The following is a description of a gene set: species: Homo sapiens Cellular Senescence Human Gene Set: REACTOME_CELLULAR_SENESCENCE, and this is the list of marker genes: H3-3A, TINF2, STAT3, H2BC12L, H2BC1, CCNE2, MAP4K4, CBX8, H3-4, H2BC12, IL1A, H2BC10, H2BC9, H2BC21, H2AC18, ACD, H4C5, CDC16, MAPKAPK3 (MAPK activated protein kinase 3), H2BC11, MIR24-2, PHC3, H3C7, PHC2, H1-0, H2BC7, RNF2, SUZ12, CDK2, RING1, MAPK11, H2BC4, H2BC26, H3C14, H3-3B, KDM6B, H3C1, H4C8, CDC26, H4C14, H1-4, TFDP2, MAP2K6, MAPKAPK2, MAPK14, H1-1, ANAPC4, ANAPC16, H4C6, CDKN2B, H4C2, H1-5, CDKN2C, ETS1, BMI1, ATM, RBBP7, VENTX, MAPK8, RPS6KA1, KAT5, ERF, MDM2, EED, MAP3K5 (NCBI Gene Id 4217), EZH2, H4C9, CDC23, CXCL8, ANAPC11, H3C2, CDKN2A (cyclin dependent kinase inhibitor 2A), ANAPC7, CDKN1A, TNRC6C, TERF1, AGO1, CABIN1, H3C3, UBC, MAPK1, CDC27, CDKN1B, RELA, H3C4, ID1, H4C15, HMGA2, MDM4, MAPKAPK5, CBX6, H2AC19, TERF2IP, MRE11, H3C12, H4C16, UBE2E1, FZR1, EHMT1, MAP2K4, TNIK, CCNA2, MAPK3, RBBP4, CCNE1, H2BC6, CDK4, H2AB1, E2F1, AGO3, UBB, CDKN2D, EP400 (E1A binding protein p400), RB1, H2BC14, MAP2K3 (mitogen-activated protein kinase kinase 3), H3C6, UBA52, RPS6KA2, H2AC7, H2AZ2, FOS, HMGA1, UBN1, H3C15, UBE2C, UBE2D1, H4C1, CCNA1, TP53, ANAPC10, H2BC8, TFDP1, ASF1A, PHC1, H3C8, CDK6, H4C12, H2AX, IGFBP7, IL6, H4C11, TXN, H2AC14, IFNB1, RAD50, TNRC6B, ETS2, JUN (NCBI Gene Id 3725), H4C3, SP1, EHMT2, MAPK9, TNRC6A, MIR24-1, ANAPC1, E2F3, H1-2, H2BC13, RPS6KA3, H2BC5, AGO4, H1-3, H2BC17, H2AC20, H3C10, H4C4, UBE2S, E2F2, ANAPC5, ANAPC2, H2BC15, ANAPC15, LMNB1, H2AC6, TERF2, MOV10, H2BC3, CBX4 (chromobox 4), H3C11, CBX2, NBN, NFKB1, MINK1, MAPK10, POT1 (NCBI Gene Id 25913), MAPK7, MAP2K7, CEBPB, H2AC4, RPS27A, HIRA, H4C13, H2AJ, H2AC8, H3C13, SCMH1